The following is a description of a gene set: species: Mus musculus from publication Yevshin I, Sharipov R, Kolmykov S, Kondrakhin Y, Kolpakov F (PMID 30445619) Mouse Gene Set: MPND_TARGET_GENES Genes containing one or more binding sites for (Mpnd) in their promoter regions (TSS -1000,+100 bp) as identified by GTRD version 20.06 ChIP-seq harmonization., and this is the list of marker genes: mt-Tp, Ccdc107, mt-Tq, mt-Tc, mt-Nd1, C920006O11Rik, mt-Tl1, mt-Ty, mt-Tn, mt-Tw, mt-Cytb, mt-Ta (mitochondrially encoded tRNA alanine)